The following is a description of a gene set: Genes predicted to be targets of miRBase v22 microRNA hsa-miR-508-5p in miRDB v6.0 with MirTarget v4 prediction scores > 80 (high confidence targets). studied in species Homo sapiens Human Gene Set: MIR508_5P from publication Chen Y, Wang X (PMID 31504780), and this is the list of marker genes: TLNRD1, HELB, CCL13, ZNF850, UBA52, JARID2, FAM168A, OSR1, EMP1, PDZD2, SERAC1, REEP6, SNAP91, AKAP12, FAM171B, LIN28B, GCH1, PRRG4, UBA3, YBEY (ybeY metalloendoribonuclease), IRGQ, CLMN, PPIP5K2, GALNT9, USP13, MSRB1, KNL1, IPO5, TMEM163, UBE2N, C4orf19, UBE4A, SORL1, PDE4DIP, NLK, DAZAP2, SLC9A6, GMNC, DOK6, KCNH8, FAR2, RNF157, SIRT5, LHFPL1, MYBPC2, DPH3P1, AMER1, DMRTA1, WDR43, FOXO1, SHCBP1, FGFBP2, TSGA10, SEH1L, VLDLR (NCBI Gene Id 7436), SDHC, PTPRJ, HAPSTR1, SLC25A30, SKIDA1, TMEM87B, DIXDC1, ZBTB33, CPEB3, ELMOD1, NOL7, ZNF568, FNDC5, CREB5, POTEA, CEP350, C6orf62 (NCBI Gene Id 81688), CYYR1, SOX11, GPATCH2L, SCML1, MYRF (NCBI Gene Id 84755), HJURP, B3GALT6, CRISP3, SART3, RAB33A (NCBI Gene Id 9363), SACM1L, SLC39A8, TFDP2, PGAP2, GREB1, AKAIN1, PLAGL2, MBNL3, TRMT9B, KLHDC8B, PDS5A, CGGBP1, APELA, NAV3, WARS2, MYO6, CYP3A4, MINDY2, ISM1